Given this list of marker genes Glrx3, Bola2, Ndufab1, Iscu, Hscb, Fdx2, Nfs1, Ndufab1-ps, Fxn, Lyrm4 (LYR motif containing 4), Glrx5, here is a description of the gene set: Mouse Gene Set: GOBP_2FE_2S_CLUSTER_ASSEMBLY The incorporation of two iron atoms and two sulfur atoms into an iron-sulfur cluster. species: Mus musculus